Given this list of marker genes Cpsf3, Zfp473, Snrpf, Ncbp2, Cpsf7, Cpsf6, Clp1, Fip1l1, Cstf2, Snrpg (NCBI Gene Id 68011), Cstf1, Pabpn1, Snrpb, Snrpe, Lsm11, Slbp, Wdr33, Cstf3, Ncbp1, Pcf11, Papola, Cstf2t, Snrpd3, Sympk, Cpsf2, Cpsf1, Lsm10, Cpsf4, Nudt21, here is a description of the gene set: Processing of Capped Intronless Pre-mRNA species: Mus musculus Mouse Gene Set: REACTOME_PROCESSING_OF_CAPPED_INTRONLESS_PRE_MRNA